Given this list of marker genes SLC29A1 (solute carrier family 29 member 1 (Augustine blood group)), SULT1A1, UGT1A10, GSTA1, PRNP, MIR27B, PDE2A, KCNQ3, SULT1C3, UGT2B7, CRYZ, CYP1B1, AS3MT, RBBP9, SULT1A2, CD69, PPM1F, CES3, CYP2C8 (NCBI Gene Id 1558), ADA, CMBL, PRKCE, CBR1, GUK1, RBM22, AIP, CYP2C18, CRHBP, ITGB3, ACSM1, NAT1, PPP1R9B, SLCO1A2, UGT1A9, CYP2B6, KCNC1, PPP1R14A, IL1B, GSTO2, PPP1R12A, CYP3A4, SULT2A1, NOS2, CYP46A1, CYB5B, TPMT, AKR1C1, ACAA1, CYP2E1, FBP1, CEBPA, UGT2B4, NQO1, HSF1, ABCC9, PPM1E (NCBI Gene Id 22843), UGT1A7, CHEK2, CYP2D6, ACSM2B, SLCO1B3, CYP2R1, ACER2, ABCC4, GSTA2, WNK4, CYP2J2, ACSL1, NUDT15, PRKAA1, BCHE, SULT1A3, CYP4F2, E2F1, TP53, PDE4B, GSTP1, GPLD1, GSTA4, GSTM4, BRAF (NCBI Gene Id 673), UGT1A1, CYP26A1, SMOX, EPHX1, AOC2, SLCO1B1, UGT1A4, ABCC3, EDN1 (endothelin 1), CYP2S1, UGT2B17, CBR3, RB1, CES2 (NCBI Gene Id 8824), AHRR, MCM7, RORA, NAT2, ADSS1, NCEH1, SLC22A1, ANKRD1, GSTM2, FMO1, AOX1, SLC28A3, POR, RAP1A, CYP1A2, MIR130B, PON3, CDH13, VAV1, ASIC2, RORC, CYP2A13, RECQL5, RNF149, MYC, PCNA, CYP2C9, SLC10A1, CYP2A6, SUFU, SLC28A2, HNF4A, ABCB1, PRKAA2, UGT1A8, UGT2B11, ABCC1, KCNQ1, SOX10, CYP1A1, GLYAT, GSTA5, KCNH2, ABCC5, SULT1B1, CYP2W1, MEF2C, N6AMT1, VKORC1, SULT1A4, ABHD10, NKX3-1, SLC22A7, UCHL1, AIM2 (NCBI Gene Id 9447), UGT2A2, ABCA1, FMO5, GSTM3, UGT2A1 (NCBI Gene Id 10941), UGT2B15, BPHL, CYP2C19, CYP2F1, UGT2A3, FMO2, UGT1A6, RAP2A, AADAC, ABCC2, ALDH3A1, GSTM1, CYP2U1, CYP3A7, LPO, CYP3A5, CAD, FUT1, SLC29A3, S100A12, CYP26B1, TLR3, FMO4, CYP2A7, GRIN1, TFRC, GAS6, REN, PDE4A, MIR378A, KCNE2 (NCBI Gene Id 9992), CYP4F12, HTR1B, UGT1A3, NOS1, EFTUD2, GSTO1 (glutathione S-transferase omega 1), AHR (aryl hydrocarbon receptor), ALDH2, CRKL, SULT1C4, NR1I2, SLCO2B1, CERS1, NFE2L2, ABCB11, ADIPOQ, VAV2, GSTA3, here is a description of the gene set: studied in species Homo sapiens Human Gene Set: GOBP_CELLULAR_RESPONSE_TO_XENOBIOTIC_STIMULUS Any process that results in a change in state or activity of a cell (in terms of movement, secretion, enzyme production, gene expression, etc.) as a result of a stimulus from a xenobiotic, a compound foreign to the organism exposed to it. It may be synthesized by another organism (like ampicilin) or it can be a synthetic chemical.